Given this list of marker genes Mymk, Cd9, Synb, Ptgfrn, Mymx, Cd81, here is a description of the gene set: studied in species Mus musculus Mouse Gene Set: GOBP_MYOBLAST_FUSION_INVOLVED_IN_SKELETAL_MUSCLE_REGENERATION A process in which non-proliferating myoblasts, after migrating to the site of injury, fuse into existing damaged fibers or fuse to myotubes to form new fibers, as part of the process of skeletal muscle regeneration. A myoblast is a mononucleate cell type that, by fusion with other myoblasts, gives rise to the myotubes that eventually develop into skeletal muscle fibers.